The following is a description of a gene set: Neighborhood of RAP1A RAP1A, member of RAS oncogene family in the MORF expression compendium Human Gene Set: MORF_RAP1A Neighborhood of RAP1A species: Homo sapiens, and this is the list of marker genes: KLHL18, CCNF, CLPX, LPGAT1, BRCA1, ZNF292, PIGR, MFN2, TAF2 (NCBI Gene Id 6873), C1orf216, TRIM27, POLR2K, KRT33A (NCBI Gene Id 3883), GRIK5, NMT1, NKRF, ATP6V0A2, BPHL, NRTN (neurturin), AMFR, ATP6V1B1, JAG1, CAMK2G, POLA1, GTSE1, AQP7, DNA2, LIAS (lipoic acid synthetase), TPP2, HIC2, NUMB, IL13, SLC25A11, OARD1, SMG1, AQP5, POP4, PIGB, ADGRL1, BAHD1, FIG4, EIF5B, ERCC2 (NCBI Gene Id 7269), DCK, AIMP1, HSPA13, EXTL3, CDYL, HTR7 (5-hydroxytryptamine receptor 7), PRIM2, RFC1, DPT, SPEF1, OPRL1, LSM1, ATRX, GRIP2, TAF5L, DDX46 (NCBI Gene Id 9879), PPP5C, PLEKHB1, IPCEF1, PIK3CB (phosphatidylinositol-4,5-bisphosphate 3-kinase catalytic subunit beta), EEF1AKMT3, CPSF4, CSTF3, LAIR1, FRYL, SLC2A1, SH2B1 (NCBI Gene Id 25970), CNOT2, SFSWAP, SLC6A11, YAF2, RBBP8, PIGF, SSTR5, SPRED2, DTNA, SLC22A6, TBC1D22A, KLHDC10, SEC23IP, PCGF1, PAXIP1, DIMT1, GPATCH8, JRK, RB1, MYCBP, MSX1, CHD3, SCAMP1, GSK3B, POLR3D, CDK13, KIAA0586, HMGN4 (NCBI Gene Id 10473), BMS1, ECE2, FNTB, UTRN, PCF11, SPAST, CHD9, SYNJ2, AGPS, PAX9, OSR1, NFYB, SEC62, MSL3, NR2C1, MC5R, SEC31A, PIK3C2A, IRF2 (interferon regulatory factor 2), PHF10, MT4, CEP350, MSH3, TTI1, PEX3, EIF4E, HOXD4, DKK4, COX6A2, TMEM94, SLC24A1, MFN1, TMEM11, RAP1A, ZNF500, LEPROTL1, HOXA11, SMC5, ENTREP1 (NCBI Gene Id 9413), INPP5E, HNRNPL, ZBTB22